The following is a description of a gene set: part of: Platelet activation, signaling and aggregation studied in species Homo sapiens Reactome Pathway: Thrombin signalling through proteinase activated receptors (PARs) Thrombin activates proteinase activated receptors (PARs) that signal through heterotrimeric G proteins of the G12/13 and Gq families, thereby connecting to a host of intracellular signaling pathways. Thrombin activates PARs by cleaving an N-terminal peptide that then binds to the body of the receptor to effect transmembrane signaling. Intermolecular ligation of one PAR molecule by another can occur but is less efficient than self-ligation. A synthetic peptide of sequence SFLLRN, the first six amino acids of the new N-terminus generated when thrombin cleaves PAR1, can activate PAR1 independent of protease and receptor cleavage. PARs are key to platelet activation. Four PARs have been identified, of which PARs 1,3 and 4 are substrates for thrombin. In humans PAR 1 is the predominant thrombin receptor followed by PAR4 which is less responsive to thrombin. PAR 3 is not considered important for human platelet responses as it is minimally expressed, though this is not the case for mouse. PAR2 is not expressed in platelets. In mouse platelets, Gq is necessary for platelet secretion and aggregation in response to thrombin but is not necessary for thrombin-triggered shape change. G13 appears to contribute to platelet aggregation as well as shape change in response to low concentrations of thrombin but to be unnecessary at higher agonist concentrations; G12 appears to be dispensable for thrombin signaling in platelets. G alpha (q) activates phospholipase C beta thereby triggering phosphoinositide hydrolysis, calcium mobilization and protein kinase C activation. This provides a path to calcium-regulated kinases and phosphatases, GEFs, MAP kinase cassettes and other proteins that mediate cellular responses ranging from granule secretion, integrin activation, and aggregation in platelets. Gbeta:gamma subunits can activate phosphoinositide-3 kinase and other lipid modifying enzymes, protein kinases, and channels. PAR1 activation indirectly leads to activation of cell surface 'sheddases' that liberate ligands for receptor tyrosine kinases, providing a link between thrombin and receptor tyrosine kinases involved in cell growth and differentiation. The pleiotrophic effects of PAR activation are consistent with many of thrombin's diverse actions on cells., and this is the list of marker genes: GNB4, MAPK1, GNA14, SRC, GNG12, GNG10, GNB2, GNG2, F2RL2 (NCBI Gene Id 2151), GNG4, GNGT2, F2, GNAQ, F2RL3, ARRB1, GNA12, F2R (coagulation factor II thrombin receptor), GNB3, MAPK3, GNG7, GNG13, ARRB2, GNA11, GNG5, GNG11, GNA15, GNG3, GNB5, GNB1, GNGT1, GNA13, GNG8